The following is a description of a gene set: species: Homo sapiens IL23 inhibitors in inflammatory bowel disease Human Gene Set: WP_IL23_INHIBITORS_IN_INFLAMMATORY_BOWEL_DISEASE, and this is the list of marker genes: IL17A, STAT5A, STAT1, CSF2, TNF, IFNG, IL12RB1 (NCBI Gene Id 3594), IL17F, STAT4, STAT3, RORC, IL22, STAT5B, JAK2, IL23A, TYK2, TLR4, IL12B